The following is a description of a gene set: A complex that possesses mannosyltransferase activity. studied in species Homo sapiens Human Gene Set: GOCC_MANNOSYLTRANSFERASE_COMPLEX, and this is the list of marker genes: DPM2, PIGM, DPM1, POMT1, DPM3, PIGV